The following is a description of a gene set: Osteoblast signaling species: Homo sapiens Human Gene Set: WP_OSTEOBLAST_SIGNALING, and this is the list of marker genes: COL1A1, IBSP, TNFSF11, PDGFRA, BGLAP, ITGB3, PDGFB, ITGAV, PTH, TNFRSF11B, PTH1R, FGF23, PDGFRB, SLC17A2